The following is a description of a gene set: Human Gene Set: GOBP_STEROID_METABOLIC_PROCESS The chemical reactions and pathways involving steroids, compounds with a 1,2,cyclopentanoperhydrophenanthrene nucleus. studied in species Homo sapiens, and this is the list of marker genes: HMGCS2, APOA1, CYB5R2, ACADVL, RDH8, SULT1E1, G6PC1, STARD3, DKK3, CYP27B1, HSD3B2, FGF19, APOL2, MIR30C1, CES1, SNAI1, OSBPL3, NPC2, SRD5A3, AKR1B15 (NCBI Gene Id 442622), ACAA2, UGT1A1, PCSK9, PMVK, SULT1A1, SLC27A5, CYP2E1, RDH16, CYP1A2, APOL1, DHCR7, TM7SF2, LCAT, APOF, CAT, LIPE, IFNG, HSD17B6, UGT2B10, PRKACA (protein kinase cAMP-activated catalytic subunit alpha), KIT, FDXR, OSBPL9, RDH5, OSBPL2 (oxysterol binding protein like 2), ABCG4 (ATP binding cassette subfamily G member 4), HSD17B14, ACLY, MIR342, PDE8B, AKR1C4, MVK, SULT1C3, ARMC5, ABCA2, CBR1, SRD5A1, ABCB11, INSIG2, MBTPS2, SPP1, HSD17B1, CYP11B1, HSD17B7, DAB2, SULT1A4, CYP2C8, SREBF2, MIR96, SULT1A2, SREBF1, GPRC6A, ANGPTL3, NR3C1, STUB1, UGT2B7, RORA, CYP17A1, FGF23, CLCN2, FAXDC2, BDH1, SHH, BAAT, REST, HSD17B12, EPHX2, SGPL1, CH25H, IL4, STARD4 (StAR related lipid transfer domain containing 4), PRKAA2, MIR98, NR0B2, NR0B1, SULT2A1, UGT1A8, SDR42E2, CYB5R3, ERRFI1, CETP, APOA4, UGT1A4, EGR1, BMP2, TIPARP, ESR1, MIR27A, GFI1, ASAH1, GAL, FDFT1, NFKB1, STS, HDLBP, INSIG1, INHBA, IGFBP7, HSD3B1, UGT2A2, QKI (QKI, KH domain containing RNA binding), MSMO1, FDX1, SULT1A3, LPCAT3, UGT2B15, PRKAG2, UGT1A7, SC5D (NCBI Gene Id 6309), MIR548P, SLC22A24, CYP3A4, AGT, HMGCR, SNX17, CYP21A2, CFTR, PLPP6, UGT1A3, MECP2, CLN6, AFP, DKKL1, GNAI1, DHRS9, CYP11B2, CYP1B1, FGF1, CYP2R1, CREB1, CLN8, CYP4V2, APOBR, SDR9C7, CYP2C9, AMACR, CYP27A1, AKR1C2, DGAT2, LIPC, YWHAH, SOAT2, PON1, APOC1, PIAS4, UGT2B11, LRP5, LIMA1, CYP2C19, MVD, HSD11B2, ERLIN2 (NCBI Gene Id 140906), ACOX2, DDX20, APOB, WNT4, CUBN, HMGCS1, CYP3A43 (cytochrome P450 family 3 subfamily A member 43), MED1, CYP3A7, HSD17B11, STAT5A, MIR27B, TTC39B, UGT2B4, LRP2, CYP2D6, SRD5A2, AKR1C3, NPC1, ATP1A1, MIR33A, GBA1, PBX1, CYP19A1, KPNB1, PIP4P1, LBR, SEC14L2 (NCBI Gene Id 85372), CYP24A1, STAR, OSBP, APOA2, CYP2A6, DHCR24 (24-dehydrocholesterol reductase), PRKG1, NPC1L1, EBP, SCP2, HSD17B3, FMO5, NR1H4, PROX1, SCARB1, NR5A1, HSD17B8, PRLR, ACADL, PRKAA1, CACNA1H, STAT5B, EDNRB, CHST10, G6PD, LEP, SNAI2, HSD17B4, ADM, NSDHL, LDLRAP1, CGA, ACOT8, ERLIN1 (NCBI Gene Id 10613), CYP46A1, OSBPL6, CYP7B1 (cytochrome P450 family 7 subfamily B member 1), NFE2L1, UGT2B17, HSD11B1 (hydroxysteroid 11-beta dehydrogenase 1), SDR42E1, LHCGR, SLC27A2, CYP2B6, UGT2B28, DHH, UGT2A1, ABCD3, CYP8B1, DHRS11, OSBPL7, VLDLR, GNB3 (NCBI Gene Id 2784), FECH, IDI1, HSD17B10, MBTPS1, SIRT1 (sirtuin 1), LHB, PPARD, MIR185, LDLR, MIR182, AQP8, FGFR1, ARV1, POR, LIPA, SULT2B1, PLEKHA1, EBPL, HSD17B2, CYP51A1, ERG28, DHRS4, CRH, ABCA5, SERPINA6, CEBPA, NR5A2, FSHB, TSKU, SMPD1, SCAP, NR1D1, C7orf50, ATP8B1, AKR1C1, CYB5R1, LMF1, MAPK1, FGFR4, PDGFRA, OSBPL1A, ACAA1, HINT2, HSD3B7, GC, PAQR3, SCNN1B, PANK2, LSS, ABCA1, OSBPL5 (NCBI Gene Id 57656), ACBD3, AGTR1, GBA2, AKR1B1, IDI2, ABCG1, CYP1A1, CYP7A1, APOE, BMP6 (NCBI Gene Id 7964), CYP11A1, DHRS2, APOA5 (apolipoprotein A5), BGLAP, LEPR, MALRD1, TSPO, GGCX, SOAT1, CYP39A1, GPR146 (NCBI Gene Id 115330), BMP5, AKR1D1, SULT4A1, RORC, FDPS, SCARF1, H6PD, CYP3A5, LGMN, TNF, NR1I2, DISP3, SQLE, SERPINA12, DGKQ